Given this list of marker genes CATSPERG, HVCN1, CATSPERB, CATSPER1, CATSPER2, CATSPER4, CATSPER3, KCNU1, CATSPERD, here is a description of the gene set: A series of receptor signaling pathways potentially govern chemical communication between sperm and egg, chemotactically guiding incoming sperm towards the oocyte. Though several substances are confirmed as sperm chemoattractant, progesterone (P) seems to be the best chemoattractant candidate for human sperm. Ion channels control the sperm ability to fertilize the egg by regulating sperm maturation in the female reproductive tract and by triggering key sperm physiological responses required for successful fertilization such as hyperactivated motility, chemotaxis, and the acrosome reaction. CatSper, a pH regulated, calcium selective ion channel, potassium channel KSper (Slo3), and Hv1, the voltage gated proton channel are involved in regulation of sperm hyperactivated motility. While progesterone, secreted by ovulated cumulus oophorus, may act as a chemoattractant for sperm cells over the short distances, a major determinant of sperm guidance over long distances in the mammalian female reproductive tract is rheotaxis. Reactome Pathway: Sperm Motility And Taxes studied in species Homo sapiens part of: Fertilization